The following is a description of a gene set: Muscle fiber cytoplasmatic inclusion bodies The presence of inclusion bodies within the cytoplasm of muscle cells. Inclusion bodies are aggregates (deposits) or stainable material, usually misfolded proteins. Human Gene Set: HP_MUSCLE_FIBER_CYTOPLASMATIC_INCLUSION_BODIES species: Homo sapiens, and this is the list of marker genes: RYR3, MYO18B, MYH7, MYPN, KY, GFPT1, DPAGT1 (NCBI Gene Id 1799), COX11, ORAI1, STIM1, ADSS1, NDUFB3, NEB, ALG2, TNNT1, KLHL41, ALG14, KBTBD13, FLNC, CFL2, TPM3, FHL1, KLHL40, NEFL, CASQ1, PYROXD1, ACTA1, SMPX (small muscle protein X-linked), TPM2, MYOT, LMOD3, GMPPB, RYR1